Given this list of marker genes RUNX1, FGG, F12, THBS1, PLAUR, KLKB1, S100A10, FGA, F11, H2BC1, PLAT, PLGRKT, MELTF, FGB, SERPINE2, CLEC3B, APOH, SERPINF2, ENO1, SERPINE1, PGK1, PLAU, DHCR24, ANXA2, CTSZ, HPN, here is a description of the gene set: Human Gene Set: GOBP_PLASMINOGEN_ACTIVATION studied in species Homo sapiens The process in which inactive plasminogen is processed to active plasmin. This process includes cleavage at an internal Arg-Val site to form an N-terminal A-chain and C-terminal B-chain held together by a disulfide bond, and can include further proteolytic cleavage events to remove the preactivation peptide.